The following is a description of a gene set: Abnormality of neuronal migration species: Homo sapiens Human Gene Set: HP_ABNORMALITY_OF_NEURONAL_MIGRATION An abnormality resulting from an anomaly of neuronal migration, i.e., of the process by which neurons travel from their origin to their final position in the brain., and this is the list of marker genes: CLP1, PEX10, DLK1, SHMT2, IFT140, NEDD4L, BICD2, CUL4B, MAN2C1, B3GALNT2, ARX, CEP41, PEX6, SCN2A, AHDC1, PIBF1, SIN3A, ZNF292, CTU2, KIF26A, CPLANE1, CCBE1, HIC1, TCTN1, GFM2, LMNB2 (NCBI Gene Id 84823), CEP135, TRAIP, MYORG, FGF8, NPHP1, TPRKB, MPDZ, CSF1R, SNRPN, ERCC1, CRB1, COL18A1 (collagen type XVIII alpha 1 chain), ATP1A3 (ATPase Na+/K+ transporting subunit alpha 3), SOX4, KAT5, FLVCR2, TUBB2B, POLR3A, NBN, CDC40, DPF2, PEX16, JAM2, POMT1, ADGRL1, MN1, PEX26, ZNF335, DOCK6, ARID1B, KIFBP, FIG4, VLDLR, CEP290, CSNK2A1, FBXO28, MED27, TUBGCP4, FRMD5, NUP37, ALDH6A1, MAST1, NUP107, ZNF526, ADD3, TMEM218 (transmembrane protein 218), FAM149B1, TMEM231 (transmembrane protein 231), TOGARAM1, GUCY2D, WDR4, PAX6, NARS1, SNAP29, LAMC3, DHCR24, DISP1, RPE65, PDHB, MKS1, GPX4, EIF2AK2, TUBGCP2, CILK1, WARS1, RAP1B, TCTN2, FH, TUBB4B, CEP104, PPIL1, SNF8, ARMC9, PEX13, TBL1XR1, IFT74, PPP1R12A, BLTP1, TRAPPC10, CSGALNACT1, PIK3R2, DHCR7, CDK5RAP2, NRCAM, SMARCA4, TP73, DCX, RPGRIP1, NEUROD2, ANKLE2, PYCR2, TUBB, AXIN1 (axin 1), IMPDH1, SMO, KCNJ13 (NCBI Gene Id 619535), ESAM (NCBI Gene Id 90952), WWOX, KIF2A, ETFDH, OCLN, CRB2, SF3B4, EPG5 (ectopic P-granules 5 autophagy tethering factor), SON (NCBI Gene Id 84155), CTNNA2, TUFM, HNRNPK, COL4A1, FGFR3, SMARCC2, PLK4, CC2D2A, SLC32A1, SASS6, SLC4A10 (solute carrier family 4 member 10), TUBA8, SHH, NAA60, ZIC2, PDHA1, KIAA0586, SLC5A6, RXYLT1, ATR, OFD1, FMR1, NFIX, ATXN2, CPT2, FOXG1, QARS1, PHC1, RELN, MCM7, LMBRD2, SUZ12, FBXL4, FKTN, VIPAS39, SPATA7, RMND1, MEG3, SPOP, MAP1B, VPS33B, OCA2, PTCH1, CIT, DMXL2, POMT2, COL4A2, PIGQ, XRCC4, CAMSAP1, CRADD, TCTN3, YWHAE (tyrosine 3-monooxygenase/tryptophan 5-monooxygenase activation protein epsilon), FTO, MYCN, TSEN15, CCND2, WT1, DHX16, NSDHL, PIK3CA, MBOAT7, KCNA1, TAF13, MLH1, GRIN1, TMX2, INTS11, LMNB1, PHOX2A, PDGFB, RTTN, TP53RK, ARHGEF9, PEX14, ASPM, PLCH1, ZNHIT3, KIF11 (kinesin family member 11), DYRK1A, WBP4, ATP6V1E1, FKRP, PIDD1, SLC25A24, PSAT1, TBC1D20, AHI1, SEPSECS, GON7, ATP6V1A, CRIPTO, ZSWIM6, MED11, SOX11, CEP120, HSD17B4, SIX3, POU4F1, CAMTA1, KLHL15, CEP152, ZEB2, TMEM237, NDE1, ACTG1, USP18, DAG1, GRM7, WASHC5, COL3A1, CCDC88A, TMEM138, PPFIBP1, DONSON, LRAT, SIK1, PDE6D, CEP295, ACTB, LIPT2, INPP5E, CDH2, TUBA1A, BMPER, KANSL1, NPRL3, FAT4, ETFA, LRPPRC, PLAA, CASK, STAMBP, CDK5, KIAA0753, POGZ, NSRP1, GMPPB, NMNAT1, DCHS1, RNU4-2, ARF1, GPSM2, C2CD3, SCN3A, PDCD6IP, SRD5A3, VRK1, ATP6V1B2, GNB1, CEP85L, TSEN54, SMARCD1, CNTNAP2, NCAPD3, USP45, WDR73, ZNF423, IQCB1, KIF7, DYNC1I2, ARL13B, CEP63, TRIM8, GLI2, ATN1, DPYSL5, ETFB, KATNIP, YRDC, ALG11, MFSD2A, LARGE1, TOPORS, GGT1, EOMES, COPB2, DHX37, RRAGC, STS, EXOSC5 (exosome component 5), VPS4A, STIL, PNKP, MCPH1, MAN1B1 (mannosidase alpha class 1B member 1), CDKL5, USP9X, THOC2, NANS, SPEN, PEX1, CPLX1 (NCBI Gene Id 10815), SARS1, KIF14, TUBGCP6, TRRAP, HYLS1, ARFGEF2, TMTC3, KNL1, PAFAH1B1, GAS1, POMK, TUBB2A, PEX2, WDR62, RPGRIP1L, MED12, TRAPPC14, TRAPPC12, ATP6V0A2, RDH12, PEX5, OSGEP, ADGRG1, AKT3, RAB3GAP1 (NCBI Gene Id 338380), TUBB3, KIF21A, PIGP, B4GAT1, SMARCE1, AKT1 (AKT serine/threonine kinase 1), PIGB, KATNB1, SLC30A9, TBC1D24, ALG12, MAPK8IP3, GDF6, FRAS1, NDN, LAGE3, CDON (cell adhesion associated, oncogene regulated), LAMA1, MAGEL2, MICU1, RNU12, MACF1, KIF5C (kinesin family member 5C), KAT6B, ARID2, SCN1B, B9D2, PDGFRB, PEX12, NPRL2, RALGAPA1, DEPDC5, CCDC22, PHGDH, TTC5, RTL1, ASXL1, MLYCD, AIPL1, CRPPA, ISCA1, TGIF1, LAMB1, KAT8, SLC20A2, PRORP, MECP2, EXOC7, PEX3, ATP1A2, RNU4ATAC, PEX19, ROBO1, PCYT1A, GMNN, CDK6 (NCBI Gene Id 1021), B9D1, GNAO1, SUFU, POMGNT2, LCA5 (NCBI Gene Id 30828), IER3IP1, RAC1, LAMA2 (laminin subunit alpha 2), CENPE (centromere protein E), SMPD4, EML1, CASP2, PI4KA (NCBI Gene Id 5297), POMGNT1, PMS2, XPR1, SMARCB1, SLC25A19, ASNS, TBR1 (T-box brain transcription factor 1), RAB3GAP2, APC2, ANKRD11, ASCC1, ODC1, DLL1, METTL5, TULP1, FLNA, TMEM222 (transmembrane protein 222), COL25A1, ARID1A, CBY1, PTEN, GLS, TSEN2, FDFT1, LONP1, FOXH1, PLP1, ARHGAP31, ADAMTS3, PRKDC (NCBI Gene Id 5591), SRPX2, INTS8, NUP133, ZMIZ1, VPS35L, TRMT10C, FLI1, ACTA2, RAB18, COG6, RPS6KA3, CRX, WDR26, PEX11B, TMEM216 (NCBI Gene Id 51259), RD3, NDUFA6, DYNC1H1, TMEM67, VAC14, RECQL4, TUBG1, MTOR, NODAL, ARL3, IBA57, TMEM107, NEK1, TSEN34, ERMARD, SLC25A22, GPHN, CSPP1